The following is a description of a gene set: Like its homolog ATF6, ATF6B is activated by cleavage in response to endoplasmic reticulum (ER) stress. In unstressed cells, ATF6B spans the ER membrane where its lumenal domain probably forms a complex with HSPA5 (BiP, GRP78). During ER stress, HSPA5 dissociates from ATF6B, exposing Golgi localization signals in the lumenal domain of ATF6B and causing ATF6B to traffic to the Golgi membrane. The Golgi-resident proteases MBTPS1 (S1P) and MBTPS2 (S2P) cleave ATF6B and release the cytoplasmic (N-terminal) domain, which contains a transcription activation domain, a bZIP dimerization domain, and a nuclear localization signal. N-glycosylation in the lumenal domain of ATF6B is required for cleavage. The cytoplasmic fragment transits to the nucleus where it acts as a weak transcription activator. By forming heterodimers with the strong activator ATF6, ATF6B may act as an inhibitory modulator of ATF6. Deletion of the ER (C-terminal) domain of ATF6B in HEK293 cells causes increased production of membrane proteins, possibly due to constitutive transit of the N-terminal domain of ATF6B to the nucleus and activation of genes. studied in species Homo sapiens part of: Unfolded Protein Response (UPR) Reactome Pathway: ATF6B (ATF6-beta) activates chaperones, and this is the list of marker genes: MBTPS2, ATF6B, MBTPS1, HSPA5